The following is a description of a gene set: studied in species Mus musculus A phosphatidylinositol 3-kinase complex that contains a catalytic and a regulatory subunit of a phosphatidylinositol 3-kinase (PI3K) enzyme, plus one or more adaptor proteins. Class I PI3Ks phosphorylate phosphatidylinositol, phosphatidylinositol-4-phosphate and phosphatidylinositol-4,5-bisphosphate, and are divided into subclasses A and B according to the type of adaptor subunit with which they associate. The class I PI3K subfamily of genes comprises members in vertebrates, worm and fly, but none in yeast. Mouse Gene Set: GOCC_PHOSPHATIDYLINOSITOL_3_KINASE_COMPLEX_CLASS_I, and this is the list of marker genes: Pik3r2, Pik3cg (NCBI Gene Id 76039), Pik3r5, Pik3r1, Pik3cd, Pik3r3, Pik3ca, Pik3cb, Pik3r6